The following is a description of a gene set: Human Gene Set: WP_PLEURAL_MESOTHELIOMA Pleural mesothelioma species: Homo sapiens, and this is the list of marker genes: PRKAG2, CDKN1A, RASSF7, NGFR, MINK1, PLCB4, FGF13, PHC1, WNT7A, SP1, ATF2 (activating transcription factor 2), CDK4, SUZ12, MAP2K5 (NCBI Gene Id 5607), NTF4, PRKAG1, CASP1, MAD2L1, PAK2, BTRC, CDH7, PRKAB1, TCF7L1, PRB1, COL4A5, EFNA4, MAP3K5, DSC3, TSC1, CCL2, WDR5, MKNK2, ACTA2, WWTR1, TCF7L2, FGF2, MAP2K7, FGF19, CD47, KMT2C, FGF14, CSNK1E, MAP2K1, TGFA, BBC3, AXIN1, CSNK2A2, EFNA1, TERT, WNT1, LAMA3, SOS1, MAPK10, FZD5, CDH17, LAMB1, YY1, FGF23, CIT, FZD10, NLRP3 (NCBI Gene Id 9558), ADAMTSL4-AS1, UHRF1, EIF4B, TSC2, EFNA5, CDH22, CTBP1, PLAU, FZD1, MAD1L1, WNT5A, RASSF2, FOXM1, SFRP2, CDH3, RNF2, FGF12, ROR1, CCND2, HCFC1, SHC1 (SHC adaptor protein 1), PAK4, PAK6, AKT3, WNT3A, CSF3, CDKN2A, PIK3CD, ROR2, WNT2B, MAPK8, LAMA2, PRKAB2, MAP3K2, MAP3K4, ITGA2, MKNK1, SENP2, RING1 (NCBI Gene Id 6015), HRAS, IGF1R, MLST8, EFNA3, KDM6A, DDIT3, FGFR1, PGF, PRB2, AJUBA, CDK7, IDO1, ANGPT1, SFRP5, SFRP4, CXCL1, MAP2K4 (mitogen-activated protein kinase kinase 4), TRAF2, IL10, ITGA4, FGF4, FRAT1 (NCBI Gene Id 10023), CDH4, DEPTOR, ULK2, IGF2, EZH2, FGFR2, PDK1, CDH5, FGF7, NTF3, SOX17, VGLL4, WNT5B, PIK3CG, ITGB1, WNT6, KDR, BECN1, BAP1, EIF4G1, RASSF6, FOXO1, STK3, FOSL1, RASSF3, MST1, ACTB, CSF1R, RAF1 (NCBI Gene Id 5894), NTRK2, PRKAA1, VEGFB, RPS6KB2, APC, LAMB2, PAK3, MAP3K10, AMOT, BARD1, RPS6KB1, ASXL1, DKK4, TNNT1, CDH18, CSNK2B, CCL5, CDH8, ITGB3, MMP2, DVL2, MDM2, PRKAA2, EGF (NCBI Gene Id 1950), PPARGC1A, RASSF4, CDH24, MET, AKT1S1, TGFB1, HBEGF, PTK2, LATS1, FRAT2, LAMC3, KIF23, RB1CC1 (NCBI Gene Id 9821), FGF8 (NCBI Gene Id 2253), AKT1, LAMA5, ITGB4 (integrin subunit beta 4), MCL1, ITGAV, MYC, MAP2K2, PDGFRA, RHEB, LIN28B, MMP3, SAV1 (salvador family WW domain containing protein 1), SELE, OGT, COL4A2, FGF9, RPS6KA3, MOB1A, DVL3, WNT2, FGFR4, CSF1 (NCBI Gene Id 1435), FGF22, ULK1, E2F1, FGF5, FZD7, FGF1, CD44, CSNK1A1L, FABP4, WNT7B, SFRP1, CTNNA3, PIK3CB, PAK5, CDH6, NTRK1, MAP3K11, COL4A4, MAP3K6, BAK1, LAMC1, CDK2, GSK3B, CDH20, RPTOR, FGF6, MAPKAPK2, HMGN1, KIT, INS, WNT16, CXCL12, RYK, MAP3K1, CDH1, DKK1, KITLG, TEK, CER1, CTNNA1, FZD2, CDH12, CUL1, FLT3, LAMA1, GABPA, CDH2, LEF1, CXCL10 (C-X-C motif chemokine ligand 10), PIGF, IGF1, MDM4, HMGB1, EPHA2 (EPH receptor A2), EFNA2, HGF, PODXL, IL1B, BAX, CCND1, MOB1B, NDRG1, CSNK1A1, MAPK14, BRCA1, CHD8, RASSF1, GRB2, ACTA1, FZD3, CTBP2, ATF3, RASSF5, DVL1, CDH16, EED, MDK, NFKB1, MAPK9, MAP3K3, SPARC (NCBI Gene Id 6678), ATG13, KREMEN1, FN1, SOST, CCNE1, MAPK1, CYCS, FZD8, ITGA1, CXXC4 (NCBI Gene Id 80319), FZD9, BAG2, ITGA6, SLC3A2, YWHAB, CTNNA2, SLC7A5, CDH10, MCU, VEGFA, BUB1B-PAK6, TEAD2, CCL4, CDH11, COL4A6, SETD2, PDGFD, NF2, RBBP4, ACTC1, WNT10A, TCF7, ITPR3, AKT2, YAP1, CSNK2A3, LAMB3, JUN, PDGFA, WNT3, BTC, LGALS9, FGF21, FZD6, PIK3CA, PDGFC, CDH13, WWC1, TTI1, LAMC2, WIF1, FLT1, FGFR3, COL4A3, CSNK2A1, ELK1, FGF20, MAP2K6, CREB1, FGF11, PAK1, CSF2, MAX, LRP6, CDH9, CDH15, DKK2, VEGFC, ANGPT4, EIF4EBP1 (eukaryotic translation initiation factor 4E binding protein 1), TEAD4, PTEN, TEAD3, ITGA3, CCND3, MAP4K3, MMP9 (NCBI Gene Id 4318), EGFR, INSR, TP53, SRC, FGF18, AREG, COL4A1, NGF, PORCN, SETDB1, TEAD1, ANGPT2, CCN2, FGF17, ATM, ACTG2, MAPK3, MMP14, BMI1 (BMI1 proto-oncogene, polycomb ring finger), MAP4K1, CTNNB1, PDGFB, MAP2K3, ACTG1, AGER, LAMA4, ADAMTS1, TELO2, BDNF, IL6, STAT1, CTHRC1, MAP3K9, RPS6, JAK1 (NCBI Gene Id 3716), MTOR, CDH19, TNIK, PRSS23, STK38L, ITGB2, RPS6KA5, MIRLET7B, WNT10B (NCBI Gene Id 82499), NOTUM, LRP5, FLT3LG, IL34, HIF1A, LIMD1, FGF3, BCL2, PDGFRB, LATS2, SERPINF1, SETD5, RPS6KA1, MAP4K2, SLC2A1, FGF10, CD274, MAP4K4, MAPK7, WNT11, WNT4, VEGFD, CXCL5, MEF2D, PRKAG3, FLT4